Given this list of marker genes HLA-DPA1, GPR183, CD53, TXNIP, LY86, CD79B, ZFAS1, ARHGDIB, CD52 (CD52 molecule), MS4A1, LCP1, CD37, SELL, BTG1, HLA-DPB1, LAPTM5, ACTB, RAC2, NAP1L1, STK17A, HLA-DQB1, IFITM2, CD69, GPSM3, ARPC1B, REL, JUNB, HLA-DQA1, MYL12A, VPREB3, COTL1, CORO1A, CXCR4, PFN1, HLA-DMA (major histocompatibility complex, class II, DM alpha, NCBI Gene Id 3108), CD74, CD48, TMSB4X, LTB, ACTG1, PTPRC, HLA-DMB, HLA-DRB1, SH3BGRL3, HLA-DRB5, CD83, SMIM14 (small integral membrane protein 14), BANK1 (B cell scaffold protein with ankyrin repeats 1), LIMD2, HLA-DRA, here is a description of the gene set: Human Gene Set: GAVISH_3CA_METAPROGRAM_B_CELLS_MHC_II In this study, an extensive analysis was conducted to define meta-programs (MPs) capturing intra-tumor heterogeneity across a spectrum of tumor types. The approach utilized non-negative matrix factorization (NMF) to analyze each cell type separately within individual tumor samples. This involved the analysis of malignant cells, macrophages, fibroblasts, endothelial cells, epithelial cells, T-cells, and B-cells. NMF was executed with varying parameter values (K=4, 5, 6, 7, 8, 9), thereby generating 39 programs for each cell type per sample. Each NMF program was summarized by the top genes based on NMF coefficients.\nRobust MPs were then delineated for each cell type using a set of stringent criteria, including recurrence within the same tumor, similarity to programs in other tumors, and non-redundancy within a tumor. Subsequently, these robust NMF programs were clustered (per cell type) based on Jaccard similarity, leading to the identification of MPs associated with each cell type.\nTo enhance the quality of the MPs, a refinement steps were undertaken, involving the removal of MPs suspected of reflecting low-quality data (with an overrepresentation of ribosomal proteins or mitochondrial-encoded genes), single-study inclusion, or similarity to miss-annotated cell types. from publication Gavish A, Tyler M, Greenwald AC, Hoefflin R, Simkin D, Tschernichovsky R, Galili Darnell N, Somech E, Barbolin C, Antman T, Kovarsky D, Barrett T, Gonzalez Castro LN, Halder D, Chanoch-Myers R, Laffy J, Mints M, Wider A, Tal R, Spitzer A, Hara T, Raitses-Gurevich M, Stossel C, Golan T, Tirosh A, Suvà ML, Puram SV, Tirosh I (PMID 37258682) species: Homo sapiens Genes upregulated in subsets of cells of a given type within various tumors